Given this list of marker genes Pdgfrb, Csf1r, Cdh3, Epha8, Map2k2 (mitogen-activated protein kinase kinase 2), Mst1r, Igfbp6, Shc1, Ephb2, Fgfr3, Ercc2, Gigyf1 (NCBI Gene Id 57330), Sos1, Fgfr2, Pdgfra, Pik3r1, Tie1, Epha7, Epha3, Flt3, Nkx3-1, Mapk3, Eif2ak3, Ntrk3, Cilp, Atxn1, Plcb1, Erbb4, Insr (insulin receptor), Erbb2, Wnt1, Zfand2b, Igf1, Phip, Tyro3, Kdr, Epha4, Map2k1, Ghsr, Mapk1, Map2k5, Egfr, Ift88, Epha5, Inppl1, Ntrk2, Ephb3, Ar, Grb10, Igf2, Pik3ca, Irs2, Ephb1, Kit, Ddr2, Mertk, Ros1, Col6a1, Tek, Ntrk1, Irs1, Insrr, Alk, Ercc1, Myorg, Musk, Igfbp4, Flt1, Ror2, Epha6, Epha2, Ret, Igfbp5, Pdpk1, Hras, Gigyf2, Ghr, Axl, Ltk, Bmp2, Igfbp3, Pou1f1, Akt1, Igfbp1, Bmp5, Fgfr1, Ghrhr, Igfbp2, Igf1r, Raf1, Ephb4, Atxn7, Met (NCBI Gene Id 194383), Trim72, Epha10, Fgfr4, Flt4, Ddr1, Grb2, Epha1, Kras, here is a description of the gene set: studied in species Mus musculus The series of molecular signals initiated by a ligand binding to an insulin-like growth factor receptor on the surface of a target cell, and ending with the regulation of a downstream cellular process, e.g. transcription. Mouse Gene Set: GOBP_INSULIN_LIKE_GROWTH_FACTOR_RECEPTOR_SIGNALING_PATHWAY